The following is a description of a gene set: Degradation of GLI1 by the proteasome studied in species Mus musculus Mouse Gene Set: REACTOME_DEGRADATION_OF_GLI1_BY_THE_PROTEASOME, and this is the list of marker genes: Psma3, Psmd1, Psmd2, Psmc2, Psmc4, Psma6, Psmb7, Psmd6, Skp1, Psma1, Psma2, Psmd14, Psmd11, Sufu, Psmd3, Psmc6, Numb, Psmb5, Psmb6, Psma5, Psmd13, Psmc5, Psma4, Psmb3, Psmc3, Uba52rt, Psmd8, Psmc1, Psmb2, Ubc, Itch, Psmb4, Psmd7, Psma7, Rps27a, Gli1, Cul1, Psmb1, Rbx1, Uba52, Ubb, Psmd12, Adrm1